Given this list of marker genes PCOLCE, COL17A1, LAMC2, COL8A1, MMP20, COL9A1, CD151, LOXL2, COL14A1, COL10A1, ITGA6, LOXL4, COL5A1, COL3A1, COL11A2, MMP7, COL11A1, COL4A5, COL4A6, COL27A1, COL18A1, COL8A2, COL2A1, COL1A2, COL5A3, COL1A1, BMP1, PXDN, COL7A1, COL4A4, COL6A3, COL9A2, TLL2, COL4A3, LOX, COL4A1, COL5A2, COL9A3, MMP9, COL4A2, ITGB4, LAMB3, CTSB, LOXL3, CTSL, COL6A6, CTSV, COL6A5, TLL1, COL15A1, PLEC, COL24A1, MMP3, DST, CTSS, LAMA3, COL12A1, MMP13, LOXL1, COL6A2, COL6A1, here is a description of the gene set: part of: Collagen formation studied in species Homo sapiens Collagen trimers in triple-helical form, referred to as procollagen or collagen molecules, are exported from the ER and trafficked through the Golgi network before secretion into the extracellular space. For fibrillar collagens namely types I, II, III, V, XI, XXIV and XXVII (Gordon & Hahn 2010, Ricard-Blum 2011) secretion is concomitant with processing of the N and C terminal collagen propeptides. These processed molecules are known as tropocollagens, considered to be the units of higher order collagen structures. They form within the extracellular space via a process that can proceed spontaneously, but in the cellular environment is regulated by many collagen binding proteins such as the FACIT (Fibril Associated Collagens with Interrupted Triple helices) family collagens and Small Leucine-Rich Proteoglycans (SLRPs). The architecture formed ultimately depends on the collagen subtype and the cellular conditions. Structures include the well-known fibrils and fibres formed by the major structural collagens type I and II plus several different types of supramolecular assembly. The mechanical and physical properties of tissues depend on the spatial arrangement and composition of these collagen-containing structures.<br><br> Fibrillar collagen structures are frequently heterotypic, composed of a major collagen type in association with smaller amounts of other types, e.g. type I collagen fibrils are associated with types III and V, while type II fibrils frequently contain types IX and XI. Fibres composed exclusively of a single collagen type probably do not exist, as type I and II fibrils require collagens V and XI respectively as nucleators. Much of the structural understanding of collagen fibrils has been obtained with fibril-forming collagens, particularly type I, but some central features are believed to apply to at least the other fibrillar collagen subtypes. Fibril diameter and length varies considerably, depending on the tissue and collagen types. The reasons for this are poorly understood.<br><br>Some tissues such as skin have fibres that are approximately the same diameter while others such as tendon or cartilage have a bimodal distribution of thick and thin fibrils. Mature type I collagen fibrils in tendon are up to 1 cm in length, with a diameter of approx. 500 nm. An individual fibrillar collagen triple helix is less than 1.5 nm in diameter and around 300 nm long; collagen molecules must assemble to give rise to the higher-order fibril structure, a process known as fibrillogenesis, prevented by the presence of C-terminal propeptides. In electron micrographs, fibrils have a banded appearance, due to regular gaps where fewer collagen molecules overlap, which occur because the fibrils are aligned in a quarter-stagger arrangement (Hodge & Petruska 1963). Collagen microfibrils are believed to have a quasi-hexagonal unit cell, with tropocollagen arranged to form supertwisted, right-handed microfibrils that interdigitate with neighbouring microfibrils, leading to a spiral-like structure for the mature collagen fibril.<br><br>Neighbouring tropocollagen monomers interact with each other and are cross-linked covalently by lysyl oxidase. Mature collagen fibrils are stabilized by lysyl oxidase-mediated cross-links. Hydroxylysyl pyridinoline and lysyl pyridinoline cross-links form between (hydroxy) lysine and hydroxylysine residues in bone and cartilage. Arginoline cross-links can form in cartilage; mature bovine articular cartilage contains roughly equimolar amounts of arginoline and hydroxylysyl pyridinoline based on peptide yields. Mature collagen fibrils in skin are stabilized by the lysyl oxidase-mediated cross-link histidinohydroxylysinonorleucine. Due to the quarter-staggered arrangement of collagen molecules in a fibril, telopeptides most often interact with the triple helix of a neighbouring collagen molecule in the fibril, except for collagen molecules in register staggered by 4D from another collagen molecule. Fibril aggregation in vitro can be unipolar or bipolar, influenced by temperature and levels of C-proteinase, suggesting a role for the N- and C- propeptides in regulation of the aggregation process. In vivo, collagen molecules at the fibril surface may retain their N-propeptides, suggesting that this may limit further accretion, or alternatively represents a transient stage in a model whereby fibrils grow in diameter through a cycle of deposition, cleavage and further deposition.<br><br>In vivo, fibrils are often composed from more than one type of collagen. Type III collagen is found associated with type I collagen in dermal fibrils, with the collagen III on the periphery, suggesting a regulatory role. Type V collagen associates with type I collagen fibrils, where it may limit fibril diameter. Type IX associates with the surface of narrow diameter collagen II fibrils in cartilage and the cornea. Highly specific patterns of crosslinking sites suggest that collagen IX functions in interfibrillar networking. Type XII and XIV collagens are localized near the surface of banded collagen I fibrils. Certain fibril-associated collagens with interrupted triple helices (FACITs) associate with the surface of collagen fibrils, where they may serve to limit fibril fusion and thereby regulate fibril diameter (Gordon & Hahn 2010). Collagen XV, a member of the multiplexin family, is almost exclusively associated with the fibrillar collagen network, in very close proximity to the basement membrane. In human tissues collagen XV is seen linking banded collagen fibers subjacent to the basement membrane. Type XIV collagen, SLRPs and discoidin domain receptors also regulate fibrillogenesis.<br><br>Collagen IX is cross-linked to the surface of collagen type II fibrils. Type XII and XIV collagens are found in association with type I and type II fibrils in cartilage. They are thought to associate non-covalently via their COL1/NC1 domains. <br><br>Some non-fibrillar collagens form supramolecular assemblies that are distinct from typical fibrils. Collagen VII forms anchoring fibrils, composed of antiparallel dimers that connect the dermis to the epidermis. During fibrillogenesis, the nascent type VII procollagen molecules dimerize in an antiparallel manner. The C-propeptides are then removed by Bone morphogenetic protein 1 and the processed antiparallel dimers aggregate laterally. Collagens VIII and X form hexagonal networks and collagen VI forms beaded filament (Gordon & Hahn 2010, Ricard-Blum et al. 2011). Reactome Pathway: Assembly of collagen fibrils and other multimeric structures